The following is a description of a gene set: from publication Chen Y, Wang X (PMID 31504780) species: Mus musculus Mouse Gene Set: MIR_7077_3P Genes predicted to be targets of miRBase v22 microRNA mmu_miR_7077_3p in miRDB v6.0 with MirTarget v4 prediction scores > 80 (high confidence targets)., and this is the list of marker genes: Dnm1l, Gemin5, Qrich1, Osbp, Ccdc68, Chfr, Atxn1, Slc2a1, Ythdf2, Sppl3, Chl1, Il13, Zfp78, Prtg, Hmgcr, Cadm2, Ppp1r9a, Unkl, Tardbp, Nr2f1, Bloc1s2, Stxbp5l, Chrna7, Cachd1, Chn2, Thbs1, Zcchc4, Poldip3, Tmem265, Wnt5a, Foxd2, Rc3h2, Fmo1, Ces1e, Mettl9, Grm5, Ppp3ca, Stag2, Usp27x, Zfp334, Map3k20, Rbbp5, Mctp1, Nsd2, Pkhd1, AI429214, Epm2aip1, Adamtsl3, Nectin3, Bdp1, Btg2, Elmo1, Susd5, Tle3, Rgs7bp, Trib2, Arl6ip6, Arl15, Rap1a, Nrsn1, Gnb1, Nup153, Crem, Nck1, Ammecr1, Slc17a8, Ephx1, Crispld1, Gid4, Il12b, Itch, Ppp4r2, Ccpg1, Timmdc1, Fgfr1op2, Tmem218, Prex2 (phosphatidylinositol-3,4,5-trisphosphate-dependent Rac exchange factor 2), Fam110c, Ppp3r1, Taf4b, Pea15a, Nedd9, Tob1, Kctd12, Csn2, Rgs13, Tnrc6b (trinucleotide repeat containing 6b), Cxcl10, Arid1b, Ctdspl2, Bend3, Cd164, Creb1, Riox2, B230217C12Rik, Mapk1, Nagk, Krtap16-3, Pcmtd1, Kpna3, Scn9a, Ssbp3, Ptprk, Pdcd6ip, Pigg, Zfp108, Isx, Cdr1, Cdk5rap1, Il36a, Plekhd1, Ebna1bp2, Fam135a, Khnyn, Ppp4r3c2, Ranbp9, Patz1, Kdm7a, Scaf8, Aagab, Ddi2, Cd44, Csnk1g3, Cog2 (NCBI Gene Id 97472), Rfx5, Itga9, Dazl, Tars1, Tspyl1, Cplx4